The following is a description of a gene set: Mouse Gene Set: GOBP_CELLULAR_RESPONSE_TO_UV_A species: Mus musculus Any process that results in a change in state or activity of a cell (in terms of movement, secretion, enzyme production, gene expression, etc.) as a result of a UV-A radiation stimulus. UV-A radiation (UV-A light) spans the wavelengths 315 to 400 nm., and this is the list of marker genes: Mmp1b, Ppid, Opn3, Mmp3, Mmp2, Opn5, Mmp1a, Cers1, Mmp9, Mme, Opn1sw, Timp1